Given this list of marker genes LYSET, ITPRID1, STK4, ERCC6L2, ACTL6A, RAB11FIP2, TNFSF14, CEACAM1, ZNF781, SLC33A1, EML1, SHC3, FTSJ1, TRERF1, ELAPOR2, FAM53B, CLCF1, HDX, PDE4D, PGR, TRIAP1, SOX6, ROBO2, TRDMT1, UNC5D, TECTB, BNC1, ACSL6, ENPP6, SLC7A11, ETS1, CREB1, KPNA1, HOXB2, IPMK, MPLKIP, BICD2, LSM11, KBTBD4, LYN, FEN1, WASHC4, SOX12, TRIB2, VANGL1, APOO, GABRA5, BLTP3A, RAG1, DOCK11, USP15, UBR3, TOM1L2, TXNDC17, CACNA1E, CYB5R4, TMOD2, ASXL2, PPM1E, MRPS2, PDE1C, UBN2, NFAT5, AMIGO1, ZNF618, HOOK3, TOMM40L, FGFR1OP2, ZNF75A, BCL11B, PTK2, SLC25A26, SLC39A6, ANKRD46, BCLAF3, NME6, B3GALNT1, TMEM154, LRRTM1, ZNF84, SLC24A2, RELN, GRIA4, NDUFA4, TNRC6B, GALNT6, MTDH, MICOS10, CCDC88A, SH2D4B, TUBGCP4, PIP4P2, CAMKK2, NDEL1, SECISBP2L, KCNH5, CCDC117, TSPAN9, MLEC (NCBI Gene Id 9761), UBE3A, GAS7, FLG2, LATS2, LIMS1, ANO3, PELI1, DGCR8, MEOX2, C11orf54 (NCBI Gene Id 28970), YEATS2, NFYA, PCBP2, VGLL3, APPBP2, CHFR, PLXNA2, LIMD1, ARHGEF39, VANGL2, AKAP17A (A-kinase anchoring protein 17A), ARPC5, ZZEF1, SAP30L, PIAS4, ADGRB3, GALNTL6, CNPY1, PARP8, NR4A3, ARL15, MTCP1, ZNF451, NPC1, LNX1, CCNY, CTBP2, here is a description of the gene set: from publication Chen Y, Wang X (PMID 31504780) Human Gene Set: MIR378A_5P Genes predicted to be targets of miRBase v22 microRNA hsa-miR-378a-5p in miRDB v6.0 with MirTarget v4 prediction scores > 80 (high confidence targets). studied in species Homo sapiens